The following is a description of a gene set: Mouse Gene Set: MIR_671_3P from publication Chen Y, Wang X (PMID 31504780) studied in species Mus musculus Genes predicted to be targets of miRBase v22 microRNA mmu_miR_671_3p in miRDB v6.0 with MirTarget v4 prediction scores > 80 (high confidence targets)., and this is the list of marker genes: Rbl2, Mfsd14a, Cxcl15, Rcan1, Odr4